Given this list of marker genes CIP2A, NECAP2, MAP3K20-AS1, LINC00943, CHCHD4, ZNHIT2, ZNF891, CST9L, SUN1, MRPL1, CAPN10, MMP20, SLC11A2, RAG1, TREM2, IGLV3-19, PMS2P4, SAMD15, DNAAF2, UBQLNL, FGF1, EREG, INHA, NEK2-DT, FLJ13224, SEMA4C, PROCA1, RBP3, IFT27, DGCR2, MGAT2, S100B, CLEC3B, LINC01310, KDM4B, CRACDL, PON2, GGACT (gamma-glutamylamine cyclotransferase), ADAM3A, IQSEC2, LAMA4, GATA5, ENTREP2, RPL13P5, BIRC6, TOM1L1, LINC02232, N4BP2L2, ISX, GLDC, IPO9 (NCBI Gene Id 55705), TRUB2, LINC00184, PLEKHG6, SLITRK2, ATP8A2, HPRT1, ART1, LINC00645, WNT2B, ITFG2, CALY, ARRDC1-AS1, CFAP210, TIGIT, NEBL-AS1, ZNF233, A1BG-AS1, TXNDC16, LINC01165, CCDC144NL-AS1, TMEM72, FOXJ3, ADAM30, BTG2-DT, DKK4, ACBD6, BPNT2, AQR, P2RX6, RANBP3L, ZNF781, SLFN13, PLAC8, TNF, ZNF268, CACNA1G, ANGPTL1 (angiopoietin like 1), RNF152 (ring finger protein 152), LEP, GCFC2, OXCT1, LINC01913, BCAM, RTP1, TARS1, ZNF770, IL22, CNTNAP4, MEP1B, PTPN22, BRINP1, KRTAP8-1, SLAMF9, GOT1L1, C3orf36, CACTIN (NCBI Gene Id 58536), CUL5, SLC2A4, ZNF197, RTBDN, MIPOL1, EOLA2-DT, OGFRP1, FBXO41, GARIN2, IBTK, DOCK10, STING1, EDNRB-AS1, LCTL, SLCO1A2, TMOD2, TSHZ1, NR5A2, SEC24B-AS1, YWHAEP7, CLEC4F, PREPL, LINC01220, H1-3, LINC01300, H2BC8, KCNG2, IRGM, DDX53, ZNF385D, DAB2IP, BBS2, PTCD2, RTCA, HMGB4, LHX6, VIT, VSTM4, CRHR2, GMEB1, DDX17, TTC21A, LINC01364, LRFN1, TRPM4, DHX32, PIK3CD-AS1, HECTD1, TRIM2 (tripartite motif containing 2), SDCCAG8, H19, RARB, KLHDC7A, CLIP4, SMIM31, NUP210P1, TSACC, SAMD13, SLC4A8, MON2, LINC03122, CENATAC, H2BW2, KRTAP4-8, FKBP6P2, FAM215A, AMT, LCN12 (lipocalin 12), SNW1, SPCS3, TPD52L3, DARS2, ALDH8A1, FMO9P, ENSG00000254531, GTF2E1, NACAD, STYX, PRDX1, LINC01304, FTO, IGFBP1, SGMS1, here is a description of the gene set: from publication Nakaya HI, Wrammert J, Lee EK, Racioppi L, Marie-Kunze S, Haining WN, Means AR, Kasturi SP, Khan N, Li GM, McCausland M, Kanchan V, Kokko KE, Li S, Elbein R, Mehta AK, Aderem A, Subbarao K, Ahmed R, Pulendran B (PMID 21743478) Systems vaccinology has emerged as an interdisciplinary field that combines systems wide measurements and network and predictive modeling applied to vaccinology. Here we used the systems vaccinology approach to study the molecular mechanisms underlying the innate responses to the trivalent inactivated influenza (TIV) and live attenuated influenza (LAIV) vaccination in humans, and to identify early gene signatures that predict the magnitude of the antibody responses to influenza vaccination. Human Gene Set: GSE29615_CTRL_VS_LAIV_FLU_VACCINE_PBMC_DN studied in species Homo sapiens Genes down-regulated in comparison of peripheral blood mononuclear cells (PBMC) from TIV influenza vaccinee pre-vaccination versus those post-vaccination.